The following is a description of a gene set: studied in species Homo sapiens Fingers that are disproportionately narrow (reduced girth) for the hand/foot size or build of the individual. Human Gene Set: HP_SLENDER_FINGER Slender finger, and this is the list of marker genes: MSH4, TRMT10A, MYLK, BCR, SATB2, FLNA (NCBI Gene Id 8272), LFNG, SPIDR, CRKL, YRDC, OTUD6B, ZNF469, CHRNG, SMAD4, SMAD2, PRKG1, CDC42BPB, PYCR2, SLC2A10, CTBP1, CPLX1, BMP1, ZEB2, FARSA, STUB1, EFEMP2, H3-3B, HNRNPH1, PEPD, HEY2, MAT2A, RECQL, HIRA, HERC1, ATRX, DSE, TRAPPC9, CHST14, PIEZO2, CBS, HYOU1, TGFB2, XYLT2, SKI, FBN1, SMARCE1, DLG4, FGFR3, PRDM5, C1R, EFEMP1, MFAP5, PAPPA2, PACS1, ACTA2, IPO8, AEBP1, TGFB3, KANSL1, OSGEP, UPF3B, PHF8, ASXL3, SMAD3, PIGG, PTCH2, ZDHHC9, FBN2, COL12A1, ELN, MRPS22, SEC24C, PLOD1, USP9X, SLC9A6, MAPK8IP3, LOX, B3GALT6, TGFBR2, BNC1, UBE3B, NPR3, NFIX, CTSC, NPR2, BICRA, ATP2B1, COL3A1, BRD4, MTR, ASCC3, SON, CIC, GNB2, ZSWIM7, SMS, SCARF2, PQBP1, COL6A2, POR, NKAP, BMP15, NUP107, THSD4, ACTG2, MYH11, PTCH1, B4GALT7, AMER1 (APC membrane recruitment protein 1), FBLN5, LAGE3, WDR73, ALG14, VPS13B, HNRNPH2, SH2B1, MTM1, ARVCF, FBXO11, RNU4-2 (NCBI Gene Id 26836), KIF22, TPR, COL2A1, PSMC3IP, FGFR2, TBX1, MAPK1, CNTN1, PPP1R15B, FSHR, UNC80, COL6A3 (collagen type VI alpha 3 chain), SUFU, NR5A1, NALCN, FOXE3, NELFA, POLR3H, NARS1, MED12, JMJD1C, RREB1, COL6A1, BMP4, UFD1, LETM1, NSD2, SOX6, EFTUD2, COL11A1, ABL1, SIN3A, DPAGT1, COMT, BGN, ASPH, GP1BB, TGFBR1, BPTF, CYP26B1